The following is a description of a gene set: The chemical reactions and pathways resulting in the breakdown of galactose, the aldohexose galacto-hexose. Human Gene Set: GOBP_GALACTOSE_CATABOLIC_PROCESS studied in species Homo sapiens, and this is the list of marker genes: GLB1L2, GLB1L3, PGM1, GLB1, GALE, GLB1L, GALT, GALK1, GALM